The following is a description of a gene set: Human Gene Set: GOMF_CALCIUM_POTASSIUM_SODIUM_ANTIPORTER_ACTIVITY species: Homo sapiens Enables the transfer of a solute or solutes from one side of a membrane to the other according to the reaction: Ca2+(in) + K+(in) + Na+(out) = Ca2+(out) + K+(out) + Na+(in)., and this is the list of marker genes: SLC24A3, SLC24A2, SLC24A4, SLC24A5, SLC24A1